The following is a description of a gene set: Reactive nitrogen species (RNS), like reactive oxygen species, have numerous target molecules in the bacterial cell, and <i>Mtb</i> has developed remedies to the most important ones of them. This is a key reason for its ability to stay alive in the hostile environment of the late phagosome within human macrophages.<br><i>Mtb</i> repairs single-base DNA damage caused by DNA alkylation; it scavenges nitric oxide with large amounts of mycothiol and methionine-rich proteins (the nitroso compounds later being reduced). Nitric oxide and peroxynitrite are also directly reduced by a battery of hemoglobins and peroxiredoxins, supported by a network of thioredoxins and respective NADPH-dependent reductases (Fang. 2004). Reactome Pathway: Tolerance by Mtb to nitric oxide produced by macrophages part of: Latent infection - Other responses of Mtb to phagocytosis species: Homo sapiens, and this is the list of marker genes: tpx, ahpE, oppB, oppC, ahpC, glbN, oppA, ggtA, msrA, oppD, trxA, adhE2, MT2748